The following is a description of a gene set: The process in which a relatively unspecialized myeloid precursor cell acquires the specialized features of a monocyte. studied in species Homo sapiens Human Gene Set: GOBP_MONOCYTE_DIFFERENTIATION, and this is the list of marker genes: DCSTAMP, JUN, VEGFA, FOXP1, HLA-DRB1 (major histocompatibility complex, class II, DR beta 1), CD74 (CD74 molecule), CSF1R, FES, FASN, ACIN1, HOXA7, APCS, PDE2A, GPR68, CSF1, THOC5, BMP4, MYH9, MED1, IRF7, INPP5D, PDE1B, CTNNBIP1, PPARG, IL34, MYC, ZBTB46, SP3, CDK6, IL31RA, MIR125B1, CSF2, IFI16, ZFP36L1, PIR, MT1G, CD4